Given this list of marker genes DYNAP, TMPRSS11D, FCHO2, CELF6, PCYOX1, FANCD2OS, ATP11C, HVCN1, ANO5, CDYL, EXTL2, B4GALT6, DGKB, RNF125, SEC24A, LAMP2, PHF12, ZNF326, DDX52 (NCBI Gene Id 113523), LAMB1, MITF, SATL1, CLDN20, HECW1, RNF220, FBN1, BIRC6, YBX3, SLC2A12, CAV2, NMI, NAALAD2, BRWD3, ZNF239, ZNF470, VCL, ITGBL1, FAM161B, ANKRD44, AKR1C3, USP32 (ubiquitin specific peptidase 32), here is a description of the gene set: studied in species Homo sapiens Genes predicted to be targets of miRBase v22 microRNA hsa-miR-4703-3p in miRDB v6.0 with MirTarget v4 prediction scores > 80 (high confidence targets). from publication Chen Y, Wang X (PMID 31504780) Human Gene Set: MIR4703_3P